The following is a description of a gene set: Mouse Gene Set: GOMF_NAD_DEPENDENT_PROTEIN_LYSINE_DEACYLASE_ACTIVITY species: Mus musculus Catalysis of the reaction: N6-acyl-L-lysyl- + NAD+ + H2O = 2''-O-acyl-ADP-D-ribose + nicotinamide + L-lysyl-., and this is the list of marker genes: Sirt5, Sirt4, Sirt1, Sirt6, Sirt7, Sirt2, Sirt3